The following is a description of a gene set: studied in species Mus musculus A process that modulates the formation of a microvillus. Mouse Gene Set: GOBP_REGULATION_OF_MICROVILLUS_ASSEMBLY, and this is the list of marker genes: Pld1, Rap1gap, Podxl, Fscn1, Prl2c2, Atp8b1, Klf5, Hnf4a